Given this list of marker genes NLRC4, PRKDC, CD70, IRAK4, SYK, IL6ST, IL2RG, DOCK8, KNSTRN, MAP3K14, IKBKB, JAK3, MYD88, FCGR3A (NCBI Gene Id 2214), XIAP, IRF1, ELF4, PIK3CG, GINS1 (GINS complex subunit 1), PTPRC, LAT, RIPK1, RAG2, PIK3R1, PSMB9, POLD1, AP3B1, CD3D, SP110, DCLRE1B, POLD3, RAG1, PIK3CD, SASH3, LYST, MCM10, PGM3, GATA2, CARD9, CBLB (NCBI Gene Id 868), MCM4, CD3E, B2M, ORAI1, DNMT3B, TOM1, here is a description of the gene set: species: Homo sapiens Abnormal natural killer cell morphology Human Gene Set: HP_ABNORMAL_NATURAL_KILLER_CELL_MORPHOLOGY An anomaly of the natural killer cell, which is a lymphocyte that can spontaneously kill a variety of target cells without prior antigenic activation via germline encoded activation receptors. It also regulates immune responses via cytokine release and direct contact with other cells.